The following is a description of a gene set: Reactome Pathway: Activation of ATR in response to replication stress studied in species Homo sapiens part of: G2/M Checkpoints Genotoxic stress caused by DNA damage or stalled replication forks can lead to genomic instability. To guard against such instability, genotoxically-stressed cells activate checkpoint factors that halt or slow cell cycle progression. Among the pathways affected are DNA replication by reduction of replication origin firing, and mitosis by inhibiting activation of cyclin-dependent kinases (Cdks). A key factor involved in the response to stalled replication forks is the ATM- and rad3-related (ATR) kinase, a member of the phosphoinositide-3-kinase-related kinase (PIKK) family. Rather than responding to particular lesions in DNA, ATR and its binding partner ATRIP (ATR-interacting protein) sense replication fork stalling indirectly by associating with persistent ssDNA bound by RPA. These structures would be formed, for example, by dissociation of the replicative helicase from the leading or lagging strand DNA polymerase when the polymerase encounters a DNA lesion that blocks DNA synthesis. Along with phosphorylating the downstream transducer kinase Chk1 and the tumor suppressor p53, activated ATR modifies numerous factors that regulate cell cycle progression or the repair of DNA damage. The persistent ssDNA also stimulates recruitment of the RFC-like Rad17-Rfc2-5 alternative clamp-loading complex, which subsequently loads the Rad9-Hus1-Rad1 complex onto the DNA. The latter '9-1-1' complex serves to facilitate Chk1 binding to the stalled replication fork, where Chk1 is phosphorylated by ATR and thereby activated. Upon activation, Chk1 can phosphorylate additional substrates including the Cdc25 family of phosphatases (Cdc25A, Cdc25B, and Cdc25C). These enzymes catalyze the removal of inhibitory phosphate residues from cyclin-dependent kinases (Cdks), allowing their activation. In particular, Cdc25A primarily functions at the G1/S transition to dephosphorylate Cdk2 at Thr 14 and Tyr 15, thus positively regulating the Cdk2-cyclin E complex for S-phase entry. Cdc25A also has mitotic functions. Phosphorylation of Cdc25A at Ser125 by Chk1 leads to Cdc25A ubiquitination and degradation, thus inhibiting DNA replication origin firing. In contrast, Cdc25B and Cdc25C regulate the onset of mitosis through dephosphorylation and activation of Cdk1-cyclin B complexes. In response to replication stress, Chk1 phosphorylates Cdc25B and Cdc25C leading to Cdc25B/C complex formation with 14-3-3 proteins. As these complexes are sequestered in the cytoplasm, they are unable to activate the nuclear Cdk1-cyclin B complex for mitotic entry.<p>These events are outlined in the figure. Persistent single-stranded DNA associated with RPA binds claspin (A) and ATR:ATRIP (B), leading to claspin phosphorylation (C). In parallel, the same single-stranded DNA:RPA complex binds RAD17:RFC (D), enabling the loading of RAD9:HUS1:RAD1 (9-1-1) complex onto the DNA (E). The resulting complex of proteins can then repeatedly bind (F) and phosphorylate (G) CHK1, activating multiple copies of CHK1., and this is the list of marker genes: RPA1, RFC4, CLSPN, ATR, CDC45, RAD9A, CDK2, RFC5, CHEK1, RPA3, MCM4, CDC25A, ORC5, ORC3 (origin recognition complex subunit 3), MCM7, CDC25C, CDC6, ORC6 (origin recognition complex subunit 6), ATRIP, MCM5, ORC4, MCM10, RAD1, RAD17, CDC7, HUS1, MCM8, RAD9B, RPA2 (replication protein A2), MCM2, ORC2, DBF4, MCM6, RFC3, RFC2, MCM3, ORC1